The following is a description of a gene set: Mouse Gene Set: CUI_B_CELL_IL36RA_RESPONSE_DN species: Mus musculus Cytokines mediate cell-cell communication in the immune system and represent important therapeutic targets. A myriad of studies have highlighted their central role in immune function, yet we lack a global view of the cellular responses of each immune cell type to each cytokine. To address this gap, the authors created the Immune Dictionary, a compendium of single-cell transcriptomic profiles of more than 17 immune cell types in response to each of 86 cytokines (>1,400 cytokine-cell type combinations) in mouse lymph nodes in vivo. A cytokine-centric view of the dictionary revealed that most cytokines induce highly cell-type-specific responses. For example, the inflammatory cytokine interleukin-1β induces distinct gene programmes in almost every cell type. A cell-type-centric view of the dictionary identified more than 66 cytokine-driven cellular polarization states across immune cell types, including previously uncharacterized states such as an interleukin-18-induced polyfunctional natural killer cell state. Genes negatively differentially expressed in cell type: B cell upon treatment with cytokine: IL-36Ra in mouse lymph nodes in vivo. from publication Cui A, Huang T, Li S, Ma A, Pérez JL, Sander C, Keskin DB, Wu CJ, Fraenkel E, Hacohen N (PMID 38057668), and this is the list of marker genes: Jun, H1f2, Fosb, Klf2, Tsc22d3, Uba52, Fos